Given this list of marker genes C2, DNAL1, DENND4C, ZMYND12, CLDN5, TBC1D23, FIRRM, TMEM107, TIMP3, CFH, SEMA4C, SERPING1, LRRK1, CCDC77, SULF1, CCDC181, SHISA2, BAIAP2L1 (BAR/IMD domain containing adaptor protein 2 like 1), VLDLR, CD99L2, NIBAN2, PHKA1, FNDC3B, STIL (NCBI Gene Id 6491), DSC3, RHOBTB1, IRS1, SNX24, DDR1, RAB12, PTPN14, PLIN2, EFS, ESAM, RAD54L, KIF2C, MFSD12, MSANTD2, TLE2, NEK2, PGR (progesterone receptor), TSGA10, PARPBP, DHX37, ACVR2A, PXDN, DEPDC1, IFT57, SEPSECS, FUCA2, RNF180, PTTG1, ETV1, APOD, CACNB2, PROCR (NCBI Gene Id 10544), PMP22, ATP13A2, KLHDC10, PSTPIP2, KIF24, ATAD5, PPM1E, MMP9, FOXN1, DUSP3, IFT81, FBLN5, KY, ARHGAP24, CCNE1, PTPRM, GRHL1, RBBP8, DESI1, DMPK, CLIC4, CLK3, CAVIN1, LTBP2, NUDT12, GDPD5, CDCP1, THRA, LIG4, FOXM1, TLR3, SYT13, LRR1, SKP2, CDC14B, CASS4, WWC2, CDK20, DPYD, IL18BP, ZNF711, ENTPD1, MAPK10, STARD8, ALOX5AP, GRIA3, CD40, BRCA2, CDS1, ZNF771, FCRLA, DOCK7, CENPO, AEBP1, HAGH, GCNT1, MMP2, SIVA1, CSRP2, TLE1, TUSC1, DNTT, FRMD4B (FERM domain containing 4B), TPD52L1, CACHD1, CRYZ, PRIM2, CLEC10A, GCAT, MOB1B, TMPRSS4, PTPN21, COL6A1 (NCBI Gene Id 1291), RRAGD, TMEM150C, MEDAG, FCMR, CNTLN, APEX1, PRNP, TCF4, PAWR, SHISAL1, ALDH5A1, DGKE, IKBIP, RNF216, MYO9A, DNA2, MOSPD2, PTPRE, EGLN3, PLA2G4A, E2F8, IQSEC2, RBM20 (NCBI Gene Id 282996), SHCBP1L, PTPN13 (NCBI Gene Id 5783), REEP3, GPATCH2, CREB3L2, RAD51AP1, DNAJC6, PYGL, TPX2, ZNF35, CRYAB, SEPTIN4, LRP1, PAPSS2, KCTD18, PHF13 (NCBI Gene Id 148479), CHST11, PLCD1, SGO2, SPO11, INHA, CEP95, RNF157, ENDOU, SEPTIN8, BMP2, AFF1, CFP, TEC, CCL17, HTRA2, SLC43A2, TPPP, SRXN1, NOTCH3, CENPE (centromere protein E), SPARC, BEX1, DTL, MICALL2, PRKD1, RMDN3, LONRF1, PGPEP1, SLC25A53, CENPF, PROKR2, TBL2, here is a description of the gene set: Human Gene Set: GSE2405_0H_VS_24H_A_PHAGOCYTOPHILUM_STIM_NEUTROPHIL_DN Genes down-regulated in polymorphonuclear leukocytes (24h): control versus infection by A. phagocytophilum. Polymorphonuclear leukocytes (PMNs) were obtained from healthy individuals in accordance with protocols approved by the Institutional Review Board for Human Subjects at the University of Minnesota and the National Institute of Allergy and Infectious Diseases. PMNs (107) were combined on ice with live S. aureus (108) or with live or heat-killed A. phagocytophilum (bacteria isolated from 5x106 infected HL60 cells for a ratio of 1 infected HL60 cell: 2 PMNs, ~ 5-20 A. phagocytophilum: PMN) in wells of a 12-well tissue culture plate (pre-coated with 20% autologous normal human serum). Unstimulated control assays received either buffer (for S. aureus comparisons) or clarified HL60 lysate (for A. phagocytophilum comparisons). Plates were centrifuged at 350 x g for 8 min at 4oC to synchronize phagocytosis and incubated at 37 deg. C in a CO2 incubator for the indicated times. At the indicated times, tissue culture medium was aspirated from the plate and PMNs were lysed directly with RLT buffer (Qiagen, Valencia, CA). Purification of PMN RNA and subsequent preparation of labeled cRNA target was performed as described in Methods. Labeling of samples, hybridization of cRNA with HU133A oligonucleotide arrays (Affymetrix, Santa Clara, CA), and scanning were performed according to standard Affymetrix protocols ( http://www.affymetrix.com/pdf/expression_manual.pdf ). Experiments were performed in triplicate, using PMNs from three healthy individuals for each treatment. studied in species Homo sapiens from publication Borjesson DL, Kobayashi SD, Whitney AR, Voyich JM, Argue CM, Deleo FR (PMID 15879137)